Given this list of marker genes FMR1, GEMIN6, GEMIN2, GEMIN7, GEMIN4, GEMIN8, SMN2, GEMIN5, DDX20 (DEAD-box helicase 20), SMN1, STRAP, here is a description of the gene set: studied in species Homo sapiens Human Gene Set: GOCC_SMN_COMPLEX A protein complex that contains the survival motor neuron (SMN) protein and at least eight additional integral components, including the Gemin2-8 and Unrip proteins; the complex is found in the cytoplasm and in nuclear Gems, and is involved in spliceosomal snRNP assembly in the cytoplasm and in pre-mRNA splicing in the nucleus.